The following is a description of a gene set: Binding to an opioid receptor. Human Gene Set: GOMF_OPIOID_RECEPTOR_BINDING studied in species Homo sapiens, and this is the list of marker genes: PENK, PDYN, GNAS, IL2, PNOC (NCBI Gene Id 5368), GNAO1, NPFFR2